The following is a description of a gene set: studied in species Mus musculus Transport of RCbl within the body Mouse Gene Set: REACTOME_TRANSPORT_OF_RCBL_WITHIN_THE_BODY, and this is the list of marker genes: Lrp2, Tcn2, Ldlrap1, Abcc1, Cd320, Abcd4, Lmbrd1